The following is a description of a gene set: studied in species Homo sapiens Genes up-regulated in comparison of naive B cell versus dark zone germinal center B cells. B cells from human tonsil and blood were sorted using flow cytometry. The human samples were processed immediately ex-vivo using markers for known B cell subsets. from publication Longo NS, Lugar PL, Yavuz S, Zhang W, Krijger PH, Russ DE, Jima DD, Dave SS, Grammer AC, Lipsky PE (PMID 19023113) Human Gene Set: GSE12845_NAIVE_VS_DARKZONE_GC_TONSIL_BCELL_UP, and this is the list of marker genes: YJU2B, ITPK1, MAPK8IP3, MGAT5, ZEB2, MCOLN1, CREB3L1, TRIL, TRAF3IP3, MANBA, RPL34, SMYD5, FCF1, ATOH1, MUC3A, GPR31, LENEP, ARMH3, ANKRD11, LRRC3, GSE1, ATF6B, AVPI1, NDEL1, METTL16, ARID3A, IKZF5, MAN2A2, SATB1, GNA12, CTNND1, RALGDS, MED13L, AKT2, ST3GAL1, IGHM, UBE2W (NCBI Gene Id 55284), ATF3, SPATA2L, MYCBP2, DNAH3, GPR153, DACT1, NDST2, PCDH11Y, BSDC1, IL13RA1, CLK4, SPAG4, APRT, WDFY3, TP63, AKAP13, FNBP4, ARHGEF10, CASP8, CHRNA9, HEBP1, RPS6KA2, CD83, KLF3, MTF1, UNC93A, TAOK1, CLDN9, TAGLN2 (NCBI Gene Id 8407), SNX27, FOXO3, RXRA, CYTL1, HCK, RPL39, ZNF12, SLC66A2, MAP3K2, MEPCE, CCZ1B, FZD5, AKAP6, EDDM3B, CCDC87 (coiled-coil domain containing 87), DCTD, BHLHE40, ROS1, TRIB2, MAFF, ESYT1, REG1CP, NUMA1, HKDC1 (hexokinase domain containing 1), KMT5B (lysine methyltransferase 5B), WWC3, TIMP1, PGAP1, CASP2, LGR4, DRAP1, KCNQ4, CENPB, MAPRE2, GSAP, C1orf115, RAB11FIP3, TMEM109, VAT1, CARD10 (NCBI Gene Id 29775), JRK, SLA (NCBI Gene Id 6503), LTBP3, PDK1, MBP, PPARD, TNFSF13, TRPV5, TNNI1, APBA3, CD6, CLDN7, ANKRD36B, CYTH4, PCIF1, ZSCAN2, TRIO, FHIP2B, PPP1R9A, CHL1, PPP1R16B, ELL2, ZNF629, INSIG1, IRF2BP1, VPS13D, AMT, ORAI2, CHI3L1, TPK1, ITPA, NEK1, LARGE1, PRSS53, FOXN2, NFKBIE, ACAN, TMBIM6, FYCO1, USP32, DHX9-AS1 (DHX9 antisense RNA 1), GYPC, TENT5A, PNRC1, VPS13C, MIS18BP1, ADRB1, NPC2, NCOA2 (nuclear receptor coactivator 2), SULT2B1, PDLIM2, TRIM22, IL36G, HLA-DQB1, PCK2, RSRC1, CRYAA (crystallin alpha A), OTUD4, MTCL1, JAK2, TNPO1, SLC12A5, DNASE2, KCNA2, EIF4EBP1, LPIN2, AQP7, TBKBP1, CCN2, NRIP1, MSN, GCK (glucokinase), KRT8P12, RPL9, APH1B, SCN3B, CDK5R1, MARCHF1, NDRG3 (NCBI Gene Id 64401), COQ8A, IRAK3, DHRS11, FHL1, BBX, DOK2, TSKU, JAM3, USP25, HERC6, SFXN3, CLCN4, IER2